Given this list of marker genes C22orf39, ZNF761, SLIT2, HNRNPC, KCNT2, TSPAN2 (NCBI Gene Id 10100), U2SURP, ITGB8, ZFHX3, NPAP1, OSBPL8, FOXN2, DMAC1, PHIP, RAB8B, BRCA2, UQCRB, TM4SF20, XPO1, NT5C1B, EGFR, SREK1, FAM120A, NIPSNAP3A, RAD23B, NIPBL, B2M, GZF1 (NCBI Gene Id 64412), PDE3B, SAMD8, CRYZ, SEPTIN14, FANCL, MEGF10 (multiple EGF like domains 10), RORA (NCBI Gene Id 6095), ZNF765, ZDHHC21, JAGN1, CLDN8, MKLN1, GOLGA8B, CHCHD3, SAR1A, TMSB4Y, APPL1, DENND1B, B3GALNT1, DLX6, C5orf47, WWTR1, FZD5, C8orf76, ASF1A, UNC80, JPH4, PRKACB, ZBED5, NR1H4, EOMES, HDAC9 (histone deacetylase 9), LRIG1, SUB1, RSAD2, TNFSF13B, C10orf88, SLC16A2, LONRF2, TAPT1, ZFAND4, SLMAP, DEUP1 (deuterosome assembly protein 1), GOLGA6L4, APH1B, SGIP1, LPCAT1, CCDC73, FAM13B, SI, FBXO38, PFN4, E2F5, LURAP1, SSH1, POLR2D, ZNF280D, TVP23A, IARS1, PCDH11Y, DDAH1 (NCBI Gene Id 23576), KLRC4, TPRG1L, ANKRD40 (NCBI Gene Id 91369), SLC25A34, AKIRIN2, ZNF813, GSDMC, TGFBR1, ATP13A4, ENOX2, PALM2AKAP2, CNOT2, CFAP418, CSNK1G3, CCDC32, PAN3, ULK2, ZNF236, RANBP9, ANO4, PCDH11X, GOLGA8A, KCMF1, SH3GLB1 (SH3 domain containing GRB2 like, endophilin B1), EIF5, EPHA5, BIVM, SBNO1, CNTN3, LHFPL3, CDK19, LRAT, NOTCH2NLA (NCBI Gene Id 388677), TMSB4X, NPAS2, MAT2B, GOLGA6L10 (NCBI Gene Id 728648), DDX18, UBAP2, SHPK, RBM26, AGO3, GANAB (glucosidase II alpha subunit), CLOCK, GOLGA6L9, TEAD1, KLHL14, NWD2, MGP, NEXMIF, ARPP19, RYK, STK33, TOR1AIP2, GIGYF2, ZNF492 (NCBI Gene Id 57615), GYPE, TRMT13, SLC4A10, REV3L, ZSCAN16, FKBP14, TOX, TMEM68, ZNF217, OTC, DDX52, JAK2, GPR83, CMPK2, GABRB1, PDE4DIP (phosphodiesterase 4D interacting protein), TUBG1, FBXL5, ZNF711, TSPAN6, RAB18, RUBCNL, SFMBT2, AMD1, MED13, TAOK3, PRIMPOL, CYP4A22, TSR1, LMAN1, here is a description of the gene set: from publication Chen Y, Wang X (PMID 31504780) Genes predicted to be targets of miRBase v22 microRNA hsa-miR-548ao-5p, hsa-miR-548ax in miRDB v6.0 with MirTarget v4 prediction scores > 80 (high confidence targets). studied in species Homo sapiens Human Gene Set: MIR548AO_5P_MIR548AX